Given this list of marker genes Usp26, Timp4, Trim39, Ubxn1, Csnk2a2, Wac, Psmf1, Ophn1, Rela, Nos2, Phb1, Anxa2, Usp19, Nqo1, Pbk, Aqp11 (aquaporin 11), Azin1, Cyp51, Rybp-ps, Ldc1, Sirt2, Mad2l1 (NCBI Gene Id 56150), Vps35, Cdk5rap3, Grin2c, Pin1, Csnk2b, Laptm4b, Caml, Rybp, Ins2, Fhit, Taf9, Fyn, Timp1, Styx-ps, Dedd, Nell1, Atraid, Map1a, Rilp, Alad, Lamp3, Psme3ip1, Il10, Hmgcr, Hfe, Ttc36, Usp8, Gipc1, Ins1, F8a, Serpine2, Usp9x, Agap2, Ogt, Tmem132a, Usp25, Usp38 (ubiquitin specific peptidase 38), Usp7, Mdm4, Mtm1, Smarcc1 (SWI/SNF related, matrix associated, actin dependent regulator of chromatin, subfamily c, member 1), Cst3, Nop53, Clec16a, Shh, Rgp1, Lrig2, Grin2a, Prkcg, Marchf7, Snca, Gabarapl2, Egfr, Svip, Fbxo43, Tlk2, Mgat3, Ptpn3, Hsp90ab1, Senp1, Snx3, Styx, Ddrgk1, Trim40, Bag5, Furin, Dysf, Smad3, Timp2, Klhl40, Usp14, Sgta, Timp3, Dab2ip, Flna, Azin2, Bag6, Nrg1, Phf20l1, Mycbp2, Sf3b3, Rpl11, Sco1, Uchl5, Ubxn2a (NCBI Gene Id 217379), Park7, Pin1rt1, Snx12, N4bp1, Mad2l2, Pabpn1l, Ccar2, Eif3h, Ric1, Adgrb1, Irak3, Ctsa, Smad4, Fmn2, here is a description of the gene set: Mouse Gene Set: GOBP_NEGATIVE_REGULATION_OF_PROTEIN_CATABOLIC_PROCESS Any process that stops, prevents or reduces the frequency, rate or extent of protein catabolic process. species: Mus musculus